The following is a description of a gene set: Genes containing one or more binding sites for (ZFP36L1) in their promoter regions (TSS -1000,+100 bp) as identified by GTRD version 20.06 ChIP-seq harmonization. studied in species Homo sapiens from publication Yevshin I, Sharipov R, Kolmykov S, Kondrakhin Y, Kolpakov F (PMID 30445619) Human Gene Set: ZFP36L1_TARGET_GENES, and this is the list of marker genes: LINC01962, PRMT5-DT, VARS2, WBP4, RAB11A, B4GAT1, LINC01623, AGBL5, SHF, MAP1LC3B, TIA1, MIR4638, SMARCC2, PAMR1, MIR4521, VTRNA2-1, DPP9 (NCBI Gene Id 91039), TRIM7-AS2, ANG, PLEKHG2 (NCBI Gene Id 64857), ZNF839, POLR3E, C2orf42, GTF2H4, PSMB3, FMC1, HCFC1, LINC01556, H3C9P, MYNN, B4GAT1-DT, LIMD1-AS1, RN7SL2, NCOA7, ILF2, VTRNA1-1, FBXO31, FMC1-LUC7L2, LINC02453, VTRNA1-3, RNASE4, RNF130, HCG14, KNL1, VTRNA1-2 (NCBI Gene Id 56663), CFAP418, RPS29, PRMT5, HMGN4, PHF12, AGBL5-AS1, SUGT1, PPP6R3, POLG-DT, SLC27A4, LRP3, BCAR3, SACM1L, HSPA6, MCRIP2, RNASE11, LTA4H, HJV (hemojuvelin BMP co-receptor), PPEF1, PIPOX, PLXDC1, LASP1, LINC00240, VPS53, POLG, LINC02739, RN7SL1, METTL26, H4C8, SRP68, SUGT1-DT, TRIM41, NDUFS7, LINC03126, ALOXE3